The following is a description of a gene set: A spliceosomal complex that contains the U2, U5 and U6 snRNPs bound to a splicing intermediate in which the first catalytic cleavage of the 5' splice site has occurred. The precise subunit composition differs significantly from that of the catalytic step 1, or activated, spliceosome, and includes many proteins in addition to those found in the U2, U5 and U6 snRNPs. Human Gene Set: GOCC_U2_TYPE_CATALYTIC_STEP_2_SPLICEOSOME species: Homo sapiens, and this is the list of marker genes: PPIE, SNRNP40, SYF2, PRPF8, AQR, SNRPD3, SNRPD1, SNRPF, SNRPE, SNRPA1, BUD31, CDC5L (cell division cycle 5 like), SNRPG, EFTUD2, SNW1, RBM22, SRRM2, SNRPB2, PRPF19, CWC22, BCAS2, CRNKL1, SNRPB, SNRPD2, XAB2, CWC15, PLRG1, PPIL1, CDC40, DHX8